Given this list of marker genes NEIL2, NTHL1, UPB1, NME7, SMUG1, UPRT, CTPS2, DTYMK, UMPS, CTPS1, UCK1, CDA, NME9, CAD, NME6, TDG, DCTD (NCBI Gene Id 1635), TBPL1 (TATA-box binding protein like 1), TYMP, DHODH, NT5M, ENPP3, DPYS, UNG, UCK2, OGG1, AK5, AK3, CMPK2, NME3, NME4, DPYD, CMPK1, MBD4 (methyl-CpG binding domain 4, DNA glycosylase), AK9, UPP1, NME1, NME2, PRPS1, NT5C, ENTPD4, SLC4A7, UPP2, NEIL1, DCK, DUT, NME5, ENTPD7, DCTPP1, TYMS, SHMT1, ENTPD5, NME2P1, UCKL1, here is a description of the gene set: species: Homo sapiens Human Gene Set: GOBP_PYRIMIDINE_NUCLEOTIDE_METABOLIC_PROCESS The chemical reactions and pathways involving a pyrimidine nucleotide, a compound consisting of nucleoside (a pyrimidine base linked to a deoxyribose or ribose sugar) esterified with a phosphate group at either the 3' or 5'-hydroxyl group of the sugar.